Given this list of marker genes Lrrc8e, Lrrc8a (leucine rich repeat containing 8A VRAC subunit A), Shoc2, Slc19a1, Lrrc8c, Abcc4, Abcc5, Slc17a9, Slc46a2, Lrrc8d, Lrrc8b, here is a description of the gene set: The directed movement of guanine nucleotides, GTP, GDP, and/or GMP, into, out of or within a cell, or between cells, by means of some agent such as a transporter or pore. species: Mus musculus Mouse Gene Set: GOBP_GUANINE_NUCLEOTIDE_TRANSPORT